Given this list of marker genes Erbb4, Htr2a, Htr2c, Fabp3, Rab38, Chp1, Nr1h4 (NCBI Gene Id 20186), Capn2, Acsl3, Adgrf5, Htr2b, Pcx, here is a description of the gene set: species: Mus musculus Any process that activates or increases the frequency, rate or extent of the chemical reactions and pathways resulting in the formation of phospholipids. Mouse Gene Set: GOBP_POSITIVE_REGULATION_OF_PHOSPHOLIPID_BIOSYNTHETIC_PROCESS